The following is a description of a gene set: SEMA3A-Plexin repulsion signaling by inhibiting Integrin adhesion Human Gene Set: REACTOME_SEMA3A_PLEXIN_REPULSION_SIGNALING_BY_INHIBITING_INTEGRIN_ADHESION studied in species Homo sapiens, and this is the list of marker genes: NRP1, RAC1, RRAS, PLXNA3, FYN, TLN1, SEMA3A, FARP2, PLXNA4, RND1, PIP5K1C, FES, PLXNA2, PLXNA1